Given this list of marker genes Snx9, Baiap2l1, A4galt, Vps4b, Bin2, Fer1l4, Prx, Serinc3, Csrp3, Cav3, Mafb, Chmp1b, Vps4a, Chmp2a, Glipr1l1, Myh9, Xrcc4, Cxcr4, Otof, Sh3gl2, Fat4, Xkr7, Fer1l6, Llcfc1, Baiap2 (NCBI Gene Id 97767), Agrn, Sh3glb1, Myh10, Pacsin3, Bin3, Frey1, Mtss2, Chmp1a, Myrf, Eqtn, Stx4a, Fnbp1l, Tlcd2, Flot1, Casp7, Ar, Sypl2, Izumo1r, Large1, Spata46, Mymx, Plscr2, Grxcr1 (glutaredoxin, cysteine rich 1), Chmp2b, Ano9, Hdac3, Tmem41b, Plscr5, Ugcg (UDP-glucose ceramide glucosyltransferase), Bin1, Vdac2, Fasl, Serinc5, Ano7, Mtss1 (MTSS I-BAR domain containing 1), S100a10, Sh3tc2, Plscr3, Spaca6 (sperm acrosome associated 6), Wdr54, Tlcd1, Plscr4, Xkr9, Anxa2, Tie1, Fa2h, Dysf, Sptb, Atp8b1, Ank2, Ano3, Sptbn1, Wasl, Iqgap1 (IQ motif containing GTPase activating protein 1), Tmem95, Serinc2, Syt11, Xkr4, Spam1, Micall1, Folr1, Tgfb2, P2rx7, Osbpl2, Sppl2c, Degs1, Smpd1, Syt7, Chmp6, Baiap2l2, Cd9, Cavin2, Spaca3, Plec, Dcst1, Ank3, Vmp1, Dcst2, Cln3, Mymk, Ptprc, Snx33, Pacsin1, Nherf1 (NHERF family PDZ scaffold protein 1), Dmkn, Ano5 (anoctamin 5), Akt2 (thymoma viral proto-oncogene 2), Stx2 (NCBI Gene Id 269706), Atp2a2, Slc4a1, Adam1a, Abcd1, Cav2, Ano4, Gsn, Epb41l3, Arl8b, Abca7, Psap, Xkr6, Col5a1, Tmeff2, Atg9a, Sytl4, Cav1, Pacsin2, Asap1, Chmp4b, Ano6, Akt1 (thymoma viral proto-oncogene 1), Pten, Chmp4c, Itga3, Crb1, Clu, 4930451I11Rik, Trim72, Colec12, Clptm1l, Fer1l5, Col6a1, Hyal5, Folr2, Catsper1, Lyzl6, Abcd2, Izumo1, Gsdmd, Pals1, Atg9b, Tpst2, Chmp7, Nox1, Degs1l, Spesp1 (NCBI Gene Id 66712), Xkr8, Ndrg1, Chmp5, Sod1, Ilk, Ehd2, Whamm (NCBI Gene Id 434204, WAS protein homolog associated with actin, golgi membranes and microtubules), S100a9, Atp10a, Casp1, Spaca5, Spta1, Chmp1b2, Trpc5, Plscr1l1, Arv1, Myof, Prf1, Plscr1, Gzmb, Chmp3, Rab3a, Dnm2, Emp2, Lyzl4, Snx18 (NCBI Gene Id 218636), here is a description of the gene set: species: Mus musculus A process that is carried out at the cellular level which results in the assembly, arrangement of constituent parts, or disassembly of the plasma membrane. Mouse Gene Set: GOBP_PLASMA_MEMBRANE_ORGANIZATION